Given this list of marker genes Dab1, Vldlr, Reln, Sh3kbp1, Fyn, here is a description of the gene set: species: Mus musculus Reelin signalling pathway Mouse Gene Set: REACTOME_REELIN_SIGNALLING_PATHWAY